The following is a description of a gene set: Human Gene Set: GOBP_TRANSCYTOSIS species: Homo sapiens The directed movement of endocytosed material through the cell and its exocytosis from the plasma membrane at the opposite side., and this is the list of marker genes: RAB17, PIGR, FCMR, CLTC, LRP2, RAB11A, RAB5A, AGER, PICALM, FCGRT, PLLP, MFSD2A, FSHR, USO1, RAB11B, VPS35, GPIHBP1, LRP1, IGF1R, GP2, LRPAP1